Given this list of marker genes BIRC2, CXCL3, RAC1, ABCC1 (ATP binding cassette subfamily C member 1 (ABCC1 blood group)), MTSS1 (MTSS I-BAR domain containing 1), GABBR1 (gamma-aminobutyric acid type B receptor subunit 1), CXCL5, NFKB2, ADAMTS3, CD9, SOD2, GCH1, SERPINB2, TNFAIP3, CDH2, MAPK9, TBC1D12, KRT7, SOD1, SELE, ANXA13, HGFAC, G0S2, CCNB1, CCNH, RABEP1, EXOSC9, CXCL8, RELB, MYBL1, CXCL1, MMP14, MAP1B, NFKBIA, RPA2, MRPL33, ICAM1, ERCC1, EGFR, CD83, MSC, HDGF, GREM1, TNFAIP2, NPAS2, ETS1, VIM, ARHGDIA, KDM6A, AP2B1, SEZ6L, CCL20, MT3, TNFAIP8, BTN3A3, IRF1, RELA, GTF2H4, PTX3, CXCL6, MMP1, LRRN3, GADD45A, VEGFA, LITAF, RND3, FN1, FGF2, IL6, EDN1, ARF6, SERPINE1, NFKB1, IER3, FGF5, GSTO1, SPTBN1 (spectrin beta, non-erythrocytic 1), TAF15, IL1B, SEC24A, FGF1, here is a description of the gene set: from publication Hinata K, Gervin AM, Jennifer Zhang Y, Khavari PA (PMID 12673201) Genes up-regulated in primary fibroblast cells by expression of p50 (NFKB1) and p65 (RELA) components of NFKB. NF-kappa B regulates normal and pathological processes, including neoplasia, in a tissue-context-dependent manner. In skin, NF-kappa B is implicated in epidermal homeostasis as well as in the pathogenesis of squamous cell carcinoma; however, its function in the underlying mesenchymal dermis has been unclear. To gain insight into NF-kappa B roles in these two adjacent cutaneous tissue compartments, NF-kappa B effects on expression of genes were determined in epidermal keratinocytes and dermal fibroblasts. Although NF-kappa B induced proinflammatory and antiapoptotic genes in both settings, it exhibited divergent effects on growth regulatory genes. In keratinocytes, but not in fibroblasts, NF-kappa B induced p21(CIP1), which was sufficient to inhibit growth of both cell types. Levels of growth inhibitory factor (GIF), in contrast, were increased by NF-kappa B in both settings but inhibited growth only in keratinocytes. These findings indicate that transcription factors such as NF-kappa B can program tissue-selective effects via both differential target gene induction as well as by inducing common targets that exert differing effects depending on cellular lineage. Human Gene Set: HINATA_NFKB_TARGETS_FIBROBLAST_UP studied in species Homo sapiens